Given this list of marker genes Gltpd2, Rtn4r, Clip3, Pla2g4a, Phb2, Il2, Traf2, Gltp, Cert1, Vdac1 (voltage-dependent anion channel 1), Map3k1, Cln8, Mag, Map1lc3b, Cel, Lamb1, Lamc1, Lyn, Vdac2, Lama1, Epdr1, Plekha8, Psap, S1pr1, Pltp, Cerkl, Cptp, Cd300lf, Laptm4b, Tnr, here is a description of the gene set: Mouse Gene Set: GOMF_SPHINGOLIPID_BINDING species: Mus musculus Binding to a sphingolipid, a class of lipids containing the long-chain amine diol sphingosine or a closely related base (a sphingoid).